The following is a description of a gene set: Human Gene Set: GOMF_TRNA_URIDINE_METHYLTRANSFERASE_ACTIVITY studied in species Homo sapiens Catalysis of the transfer of a methyl group from a donor to a uracil residue in a tRNA molecule., and this is the list of marker genes: ALKBH8, TRMT44, TRMT2B, TRMT2A, TRMT9B